Given this list of marker genes Mif, Set, Psme2, Fdps, Tuba4a, Hspa8, Cfl1, Ppa1, Pa2g4, Ran, Psmb5, Ncl, Atp5mc1, Ndufb4, Banf1, Nme1, Pfn1 (profilin 1), Ranbp1, Eif4a1, Fkbp4, Nifk (NCBI Gene Id 98469), Psmb8, Socs1, Rexo2, Cish, Uchl3, Txn2, Socs2, Psmb10 (NCBI Gene Id 19171), Dph5, Ppp1r14b, Sae1, Med8, Atp5f1b, Macroh2a1, Hspa9, Ptma, Eif5a, Cyba (NCBI Gene Id 13057), Ccnd2, Eno1, Npm3, Tuba1b, Bst2, Ppan, Ifi35, Gpatch4, Hsp90ab1, Dctpp1, Lta, Bcl2, Cct8, Mettl1, Hspe1, Tubb4b, C1qbp, Calr, here is a description of the gene set: Genes positively differentially expressed in cell type: Treg upon treatment with cytokine: IL-7 in mouse lymph nodes in vivo. studied in species Mus musculus from publication Cui A, Huang T, Li S, Ma A, Pérez JL, Sander C, Keskin DB, Wu CJ, Fraenkel E, Hacohen N (PMID 38057668) Mouse Gene Set: CUI_TREG_IL7_RESPONSE_UP Cytokines mediate cell-cell communication in the immune system and represent important therapeutic targets. A myriad of studies have highlighted their central role in immune function, yet we lack a global view of the cellular responses of each immune cell type to each cytokine. To address this gap, the authors created the Immune Dictionary, a compendium of single-cell transcriptomic profiles of more than 17 immune cell types in response to each of 86 cytokines (>1,400 cytokine-cell type combinations) in mouse lymph nodes in vivo. A cytokine-centric view of the dictionary revealed that most cytokines induce highly cell-type-specific responses. For example, the inflammatory cytokine interleukin-1β induces distinct gene programmes in almost every cell type. A cell-type-centric view of the dictionary identified more than 66 cytokine-driven cellular polarization states across immune cell types, including previously uncharacterized states such as an interleukin-18-induced polyfunctional natural killer cell state.